The following is a description of a gene set: species: Homo sapiens Human Gene Set: HP_HYPERACUSIS Hyperacusis Over-sensitivity to certain frequency ranges of sound., and this is the list of marker genes: GTF2IRD2, FLII, TRIO, MLXIPL, RFC2, BUD23, EIF4H, ELN, CLIP2, VPS37D, NCF1, TBL2, GM2A, GTF2IRD1, HEXB, FKBP6, UBAP2L, GTF2I, DNAJC30, BAZ1B, RAI1, STX1A, NAA60, TMEM270, PPM1D, LIMK1, DEAF1, IQSEC2, METTL27